Given this list of marker genes MIR223HG, MYD88, MIR9-1, MIR199A2, CCL3, CXCL8, MIR126, TAB1, MIR16-2, CHUK, VCAM1, TAB2, MAPK8, NFKB1, MIR203A, TRAF3, MIR199A1, IL6, TRAF6, MIR106A, MIR21, MIR200B, MIR122, MAPK14, IRAK1, LCN2, MIR145, MIR29A, MIR125B2, IKBKG, MIR125B1, TNF, MIR200C, RELA, MIR203B, MIR187, RELB, MIRLET7I, IRAK4, TLR8, MIR106B, IRF1, IKBKB, REL, IRF7, MIRLET7E, GZMB, TLR7, NFKB2, MIR19A, NFKBIA, MAP3K7, TLR4, MIR758, IL10, IRF5, MIR149 (microRNA 149), IL1A, CCL4, MIR146B, MIR16-1, MIR155, MIR155HG, ICAM1, ELANE, here is a description of the gene set: miRNA role in immune response in sepsis studied in species Homo sapiens Human Gene Set: WP_MIRNA_ROLE_IN_IMMUNE_RESPONSE_IN_SEPSIS